Given this list of marker genes Duox2, Noxa1, Ncf2, Cybb, Nox4, Nox3, Cyba, Rac2, Nox1, Ncf4, Ncf1, Duox1, Noxo1, here is a description of the gene set: studied in species Mus musculus Mouse Gene Set: GOCC_NADPH_OXIDASE_COMPLEX A enzyme complex of which the core is a heterodimer composed of a light (alpha) and heavy (beta) chain, and requires the cytosolic regulatory subunits at least NCF1/p47-phox, NCF2/p67-phox, NCF4/p40-phox and the small GTPase RAC1 or RAC2 for activity. Functions in superoxide generation by the NADPH-dependent reduction of O2.